Given this list of marker genes FOXA1, IRF2BP1 (interferon regulatory factor 2 binding protein 1), S100P, AGR2, LITAF, MUC4, PERP, BIK, ZNF629, SYTL2, APOBEC3A, EXPH5, GPR87, IL1R1, NDUFA2, KCNE3, SPINT2, IER3 (NCBI Gene Id 91950), MUC16, ATP12A, KRT18, VAMP8, ADRB1, SYT8, GALNT4, GRHL2, C19orf33 (chromosome 19 open reading frame 33), MAFF, UPK1B, ABHD11, SPRR3, TMC5, NHP2, CXCL17, LCN2, CEACAM6, WFDC21P (NCBI Gene Id 650626), PLAC8, KRT8, FAM83A, KRT19, CX3CL1, SH2D4A, CP, ADIRF, SLPI, MMEL1, SYTL1 (synaptotagmin like 1), C6orf132, TLR5, EPS8L1 (NCBI Gene Id 54869), VSIG2, CXCL14, GFUS, PRSS8, TFF3, IER2, LYPD2, TSTD1, BBOX1, ENSG00000268833, CD55, TEX101, A4GALT (alpha 1,4-galactosyltransferase (P1PK blood group)), NR4A2, ZNF750 (zinc finger protein 750), ASS1, CD82, SPRR1B, LY6E, TACSTD2, MUC5B, ZDHHC12, IGIP, SECTM1, GGT6, TJP3, GPRC5A, FAM83H, LGALS3, SYTL5 (synaptotagmin like 5), LYPD3, SLC30A4-AS1, RASSF7 (NCBI Gene Id 8045), GPR108, ADGRF1, SERPINB2 (serpin family B member 2), SPATA2, GDF15, BSPRY, NR2F6, MGST1, H2AJ, SERINC2 (NCBI Gene Id 55431), CLDN4, FXYD3, MHENCR (melanoma highly expressed competing endogenous lncRNA for miR-425 and miR-489, NCBI Gene Id 100505771), GADD45B, PRSS22, MAL2, ANXA1, ZNF703, IL1RN, TINCR, GPC1-AS1, ESRP2, NHSL3, SDC4, SMIM22, RARRES1, S100A9, MYH14, CD9, IER3IP1, RHOV (ras homolog family member V), KRT4, MPZL2 (NCBI Gene Id 95160), ASPG, CHI3L1, DSC3, ST6GALNAC1, PSD4, RAB25, ENC1, PPP1R3B, CYP4B1, TMEM54, RAB11FIP1, KRT13, CLDN1, SERPINA1, CYB561, TMEM30B, TMEM184A, FHL1P1, NECTIN4, GCNT3, CFB, TMEM191A, EFCAB15P, CCL28, SLC34A2, CDKN2B, IKZF2, STAP2, SCGB1A1, S100A8, B3GNT3, STARD10, F2RL1, POLR2J3, MUC15, CYP2F1, KRT7, EVPL, AGA, STEAP4, B4GALT5, SLC44A4, KRT23, CHMP2A, TRIM29, CXCL8, EPCAM, HDAC11 (NCBI Gene Id 79885), HEBP2, CRIP1, WFDC2, MSLN, EPS8L2, MUC20, TMPRSS4, GBP3, CDKN2A, AGR3, TMC4, NHERF1, SERPINB1, TSPAN1, PKP1, BCAS1, PLA2G2A, KRT5, CAPN13, KCP (NCBI Gene Id 378173), ANKRD35, FAM3D, F3, SCGB3A1, DSP, UBXN10 (UBX domain protein 10), AQP3, MCL1, CLDN3, MUC1, SPINT1, ELF3, NANS, MYCL (MYCL proto-oncogene, bHLH transcription factor), TMPRSS2, SDR16C5, EHF, PSCA, RNPEPL1, CLIC3, TNFSF15, JUNB, UPK2, PLAAT4, ENPP5, SLC16A5, SCEL, ST14, PPDPF, ATF3, LINC01484, PIGR, C1orf116, SDC1, AGTRAP, S100A6, LINC01019, CLDN7, CAPNS2, ANXA3, LIPH, ITPKC, GABRP, ACSM3, GRHL2-DT, H19, GJB2, CLCF1, CXCL1 (NCBI Gene Id 2919), SMIM5, SLC35C1, KRT15, NFKBIA, SFN, WNT4, VTCN1, TTC22, ZNF689, ERBB2, MACC1, HOPX, here is a description of the gene set: The gene expression program underlying the specification of human cell types is of fundamental interest. The study authors generated human cell atlases of gene expression and chromatin accessibility in fetal tissues. For gene expression, the study authors applied three-level combinatorial indexing to >110 samples representing 15 organs, ultimately profiling ~4 million single cells. The study authors leveraged the literature and other atlases to identify and annotate hundreds of cell types and subtypes, both within and across tissues. Our analyses focused on organ-specific specializations of broadly distributed cell types (such as blood, endothelial, and epithelial), sites of fetal erythropoiesis (which notably included the adrenal gland), and integration with mouse developmental atlases (such as conserved specification of blood cells). These data represent a rich resource for the exploration of in vivo human gene expression in diverse tissues and cell types. from publication Cao J, O'Day DR, Pliner HA, Kingsley PD, Deng M, Daza RM, Zager MA, Aldinger KA, Blecher-Gonen R, Zhang F, Spielmann M, Palis J, Doherty D, Steemers FJ, Glass IA, Trapnell C, Shendure J (PMID 33184181) Marker genes curated from the annotated cluster as represented in the Descartes Human Gene Expression During Development database. species: Homo sapiens Human Gene Set: DESCARTES_FETAL_EYE_CORNEAL_AND_CONJUNCTIVAL_EPITHELIAL_CELLS